Given this list of marker genes BCL11A, ZNF296, DCC, CARM1, FAT3, ARF6, MGARP, KIAA0319, here is a description of the gene set: Human Gene Set: GOBP_NEGATIVE_REGULATION_OF_DENDRITE_DEVELOPMENT studied in species Homo sapiens Any process that stops, prevents, or reduces the frequency, rate or extent of dendrite development.